The following is a description of a gene set: Binding to thiamine pyrophosphate, the diphosphoric ester of thiamine. Acts as a coenzyme of several (de)carboxylases, transketolases, and alpha-oxoacid dehydrogenases. Mouse Gene Set: GOMF_THIAMINE_PYROPHOSPHATE_BINDING species: Mus musculus, and this is the list of marker genes: Ilvbl, Tktl2, Tkt, Ogdh, Tktl1, Dhtkd1, Hacl1